Given this list of marker genes PRKG1, ADORA2B (NCBI Gene Id 136), IRAG1, MIR153-1, RGS2 (NCBI Gene Id 5997), GUCY1A1, SOD1, here is a description of the gene set: studied in species Homo sapiens Human Gene Set: GOBP_RELAXATION_OF_VASCULAR_ASSOCIATED_SMOOTH_MUSCLE A negative regulation of smooth muscle contraction resulting in relaxation of vascular smooth muscle. The relaxation is mediated by a decrease in the phosphorylation state of myosin light chain. This can be achieved by removal of calcium from the cytoplasm to the sarcoplasmic reticulum lumen through the action of Ca2+ ATPases leading to a decrease myosin light chain kinase activity, and through calcium-independent pathways leading to a increase in myosin light chain phosphatase activity.